The following is a description of a gene set: Human Gene Set: REACTOME_RELAXIN_RECEPTORS Relaxin receptors species: Homo sapiens, and this is the list of marker genes: RXFP2, RXFP1, RLN3, RXFP3, INSL3, RXFP4, RLN2, INSL5